The following is a description of a gene set: species: Mus musculus Mouse Gene Set: GOMF_PRERIBOSOME_BINDING Binding to a preribosome., and this is the list of marker genes: Tma16, Zfp593, Afg2b, Gtpbp4, Zfp622, Afg2a, Cinp, Nvl